Given this list of marker genes SRSF1, REXO2, UQCC3, CRCP, PTRH1, DAP3 (death associated protein 3, NCBI Gene Id 7818), PCDHA12, MMP17, TAC1, CA2 (carbonic anhydrase 2), TWF1, RPL7L1, DPP6, DDX51, CHST2, IRAK1, TMEM123, CWC15, STMN1, TMEM234, ZKSCAN3, ACTG2, AMELX, AARD, MYL7, LSM3, MYPOP, SCAF8, MRPL36, PAPOLA, AMOTL2, COMMD9, PTHLH, TBC1D23, MEOX1, TMEM126A, FDXR, S100A8, GNAT2, UBD, STRBP, CACYBP, SALL4, SNRPA1, SLC37A4, APOBEC1, MAP1LC3B, NIPSNAP2, GLA, TBL3 (NCBI Gene Id 10607), RER1, COLGALT1, XRN2, ATP6V1D, S100PBP, NUP93, MED10, MGST1, HOXD11, NUDT19, UHMK1, RSPH3, NUDT4, ATP11A, HOMER1 (homer scaffold protein 1), ZBTB45, COA6, LACTB2, TPRG1L, HLA-C, RPS11, CNN2, UMOD, HNRNPH3, ZSCAN12, ISCA2, THAP7, MME, MRPL18, VAMP5, LGALS2, GLTP, MRPL2, HEBP1, GABRG3, COIL, DRG1, HYPK, ELOC, SHOC2, THOC3, TTK, ZKSCAN1, SLC7A6, ACSL5, VRK1, GALNT6, TBR1, PTPN9, DGUOK, C1R, EIF1B, MDM4, VMP1, SRP9, DCLRE1A, EPHA7, TTC14, HTR2B, PSMG2, CDC45, CXXC5, XDH, BMX, RCOR1, SP3, TFR2, DERL2, RARS2, CDC23, SERPINE1, PHF5A, AXIN2, NAT2, NME1, IRAG1, WDR55, TCF19, LARP4B, TXNIP, MR1, CYP1A2, RNF181, RAMAC, POLD2, SMARCD2, TUBGCP4, MIX23, SYT10, PTCD2 (pentatricopeptide repeat domain 2), HOXA1, PSMC3IP, D2HGDH, AP4S1, BAAT, CRP, SKAP2, TSNAX, CMTM7, CYP7B1, APEX1, CLTA, REG3G, GGPS1, SYNJ2, RPP30, SFRP1, MCM5, ALG2, SCAND1, UBE2L6, KLF2, PSMB10, NCK1, BMP2K, REM1, LARS1, LXN, ISG15, ASF1B, GHR, ACLY, IER2, PIK3C3, DPH5, RPA2, CDK1, SLC34A2, RTTN, C3, TPM3, VAV2, SULT1B1, CASP1, CCL21, DNM2, HNF4G (hepatocyte nuclear factor 4 gamma), NAV2, MSTN, POLR2I, NOMO1, RIT2, QNG1, SYNRG, SAMHD1, PYGB, PAX9, WIPF1, SLIRP, NDE1, here is a description of the gene set: Human Gene Set: GSE27092_WT_VS_HDAC7_PHOSPHO_DEFICIENT_CD8_TCELL_DN from publication Navarro MN, Goebel J, Feijoo-Carnero C, Morrice N, Cantrell DA (PMID 21399638) Genes down-regulated in wildtype cytotoxic T lymphocytes versus those overexpressing phosphorylation deficient form of HDAC7. The present study reports an unbiased analysis of the cytotoxic T cell serine-threonine phosphoproteome using high resolution mass spectrometry. Approximately 2,000 phosphorylations were identified in CTLs of which approximately 450 were controlled by TCR signaling. A significantly overrepresented group of molecules identified in the phosphoproteomic screen were transcription activators, co-repressors and chromatin regulators. A focus on the chromatin regulators revealed that CTLs have high expression of the histone deacetylase HDAC7 but continually phosphorylate and export this transcriptional repressor from the nucleus. HDAC7 dephosphorylation results in its nuclear accumulation and suppressed expression of genes encoding key cytokines, cytokine receptors and adhesion molecules that determine CTL function. The screening of the CTL phosphoproteome thus reveals intrinsic pathways of serine-threonine phosphorylation that target chromatin regulators in CTLs and determine the CTL functional program. We used Affymetrix microarray analysis to explore the molecular basis for the role of HDAC7 in CTLs and the impact of GFP-HDAC7 phosphorylation deficient mutant expression on the CTL transcriptional profile. species: Homo sapiens